The following is a description of a gene set: from publication Heidenblad M, Lindgren D, Veltman JA, Jonson T, Mahlamäki EH, Gorunova L, van Kessel AG, Schoenmakers EF, Höglund M (PMID 15688027) DNA copy number alterations are believed to play a major role in the development and progression of human neoplasms. Although most of these genomic imbalances have been associated with dysregulation of individual genes, their large-scale transcriptional consequences remain unclear. Pancreatic carcinomas frequently display gene copy number variation of entire chromosomes as well as of chromosomal subregions. These changes range from homozygous deletions to high-level amplifications and are believed to constitute key genetic alterations in the cellular transformation of this tumor type. To investigate the transcriptional consequences of the most drastic genomic changes, that is, genomic amplifications, and to analyse the genome-wide transcriptional effects of DNA copy number changes, we performed expression profiling of 29 pancreatic carcinoma cell lines and compared the results with matching genomic profiling data. We show that a strong association between DNA copy numbers and mRNA expression levels is present in pancreatic cancer, and demonstrate that as much as 60% of the genes within highly amplified genomic regions display associated overexpression. Consequently, we identified 67 recurrently overexpressed genes located in seven precisely mapped commonly amplified regions. The presented findings indicate that more than one putative target gene may be of importance in most pancreatic cancer amplicons. Up-regulated genes whose expression is associated with amplification of the 8q24 chromosome region in pancreatic cancer cell lines. studied in species Homo sapiens Human Gene Set: HEIDENBLAD_AMPLICON_8Q24_UP, and this is the list of marker genes: C8orf76, UNC13B, CRYBB2P1, TUBBP5, MYO6, AEN, CDC25C, TEX264, UBE2R2, AHSA1 (activator of HSP90 ATPase activity 1), ZNF621, IFRD2, KIF22, TMEM38B, MAPKAPK3, ALAD, NPLOC4, SLC36A4, STPG4, ABL1, ALKBH1, BCL6B, SH3BP5, PDK1, MED6, SMN2, MAP4, H2AC17, MTA3, DNASE1, SEC22C, TINAG, LONP1, TRAPPC13 (NCBI Gene Id 80006), HLF (NCBI Gene Id 3131), DYNC1H1, GTF2H2, BAG5, SLC16A1, CCSAP, TROAP